The following is a description of a gene set: Processing and activation of SUMO species: Mus musculus Mouse Gene Set: REACTOME_PROCESSING_AND_ACTIVATION_OF_SUMO, and this is the list of marker genes: Sumo1, Sumo3, Rwdd2b, Sumo2, Ube2i, Sae1, Senp2, Senp1, Uba2, Senp5